The following is a description of a gene set: Mouse Gene Set: CUI_T_CELL_CD4_IFNB_RESPONSE_DN species: Mus musculus Cytokines mediate cell-cell communication in the immune system and represent important therapeutic targets. A myriad of studies have highlighted their central role in immune function, yet we lack a global view of the cellular responses of each immune cell type to each cytokine. To address this gap, the authors created the Immune Dictionary, a compendium of single-cell transcriptomic profiles of more than 17 immune cell types in response to each of 86 cytokines (>1,400 cytokine-cell type combinations) in mouse lymph nodes in vivo. A cytokine-centric view of the dictionary revealed that most cytokines induce highly cell-type-specific responses. For example, the inflammatory cytokine interleukin-1β induces distinct gene programmes in almost every cell type. A cell-type-centric view of the dictionary identified more than 66 cytokine-driven cellular polarization states across immune cell types, including previously uncharacterized states such as an interleukin-18-induced polyfunctional natural killer cell state. from publication Cui A, Huang T, Li S, Ma A, Pérez JL, Sander C, Keskin DB, Wu CJ, Fraenkel E, Hacohen N (PMID 38057668) Genes negatively differentially expressed in cell type: CD4+ T cell upon treatment with cytokine: IFN-β in mouse lymph nodes in vivo., and this is the list of marker genes: Smad7, Dusp2, Cotl1, Snapc5, Eif4g2, Nop10, Set (NCBI Gene Id 80406), Fos, Tspan32, Gimap6, Entrep3, Lat, Zfp36l2, Crip1, Tecpr1, Capns1, Ift20, Izumo1r, Trat1, Tbc1d10c, Tle5, Kras, Cd44, Arf5, Dnm2, Bnip3l, Lasp1, Sh3kbp1, Fxyd5, Myh9, Atp5pd, Myl6, Cenpx, Rasgrp1, Tacc1, Ypel3, Hmgb1, Atox1, Itga4, Rasgrp2, Septin9, Chd4, Bcl11b, Emp3, Themis, Dgkd, Pak2, Ftl1, Ier2, Ccr7, Pik3ip1, Ripor2, Lgals1, Ppp1ca, Slc38a1, Kif21b, Septin7, Gapdh, Gm2a, Neurl3, Ankrd44, S100a11, Ctsd, Grk2, Gtf2i, Tcf7, Reep5, Ddit4, Gramd1a, Ing1, Pbrm1, Rasal3, Orai2, Tnik, Arpc1b, Mettl26, Vdac1, Thy1, Cdk2ap2, Fyb1, Nt5c, Smc4, Stk38, Rflnb, Stk17b, Sh3bgrl3, Anp32a, Cd4, Spn, Cd3g, Gmfg, Bin1 (bridging integrator 1), Cd52, Fmnl1, Lamtor4 (NCBI Gene Id 66096), Ralbp1, Atp1b1, Grk6, Satb1, Calm3, Ppp1r15a, Pdlim4, Dap, Higd2a, Itgb2, Prex1, Adcy7, Itpkb, Zmiz1, Srpk1, S1pr1, Fam78a, Ramp1, Sugt1, Ahnak, Trac, Tagln2 (NCBI Gene Id 78395), Ddx3x, Eif4a2, Cdkn1b, Lef1, Actr3, Cd37, Ube2h (ubiquitin-conjugating enzyme E2H), Galnt6, Ppp1r14b, Ppp2r5a, Arglu1, Id3, Snrnp70, Pdcd4, Eef2 (NCBI Gene Id 13629), Arhgdib, Nme1, Ddx5, Top2b, Pfn1, Tet3, Gimap3, Cdc37, Smc6, Tesc, Ppp1r18, Stmn1, Retreg1 (NCBI Gene Id 66270), Klhl24, Trib2 (tribbles pseudokinase 2), Capg, Tnfaip8, Itm2a, Cd5, Rgcc, Klf2, Btg2, Als2cl, Dynll1, Ppdpf, Ifi27, Atad2, Cnn2, Tln1, Aprt, H2az2, Maz, Hnrnpu, Klf6, Cd28, S100a10, Clta, Tsc22d3, Adgre5, Rac2, Cd6, Cfl1, Hnrnpa2b1, Gpx4, Il27ra, Ptpn7, Gnai2, Acp5, Calm2, H3f3a, Actg1, S100a13, Nsd1, Rbm39, Ttc3, Ncor1, Mrpl33, Gpx1, Ppia, Macf1, Ssbp3, Chd3, Lcp1, Rgs2, Ucp2, Actn1, Srpk2, H2aj, Saraf, Pnrc1, Tgfb1, Selenok, Bin2, Sfpq, Il7r, Flna, Luc7l3, Bzw2, Kmt2e, Klf3, Kmt2c, Luc7l2, Junb, Gpsm3, Ccdc88c, Tgfbr2, Hnrnpa3, Ets1, Ankrd12, Fkbp1a, Tubb5, Mxd4